Given this list of marker genes DNAJC1, RCN1, ZNF277, GATAD1, ST20, RALGAPA1, WARS1, SCYL2, P2RX4, SYTL1, GRPEL2, FBXL13, MFSD8, CEP120, KLHL24, NUP214, DAPP1, ATXN1, ACAA2, PSTPIP1, CARD19, ENTPD4, PRNP, PIERCE2, SEMA4A, CHD6, RAD51D, ADGRE2, CCDC92, SPG11, WDR33, BBLN, AAK1, RPS6KA5, ARRDC4, ZNF518A, NAP1L1, KLF10 (NCBI Gene Id 7071), GKAP1, TMEM52B, HMGCL, INAFM1, BAZ2B, RGS2, NEAT1, TP53I13, PTPN23, RETREG1, JAK1, MIR223, HCG18, NDE1 (nudE neurodevelopment protein 1), VEGFA, NFAT5, PKD1, CYLD, PTPRE, TRIM38, C1orf74, FTH1P5, STK4, ZNF174, TRIB3 (tribbles pseudokinase 3), GABARAPL1, TCF4, OSBPL11, ZNF536 (zinc finger protein 536), TIMM9, RAB3IP, SERPINB1, RSPH3, ASPHD2, ZMYM5, SH3PXD2A, MBNL2, FSD1L, NBR1, TPM4, CDK19, MYO1B, CREBL2, MGC16275, RIOK3, POC5, CD48, PHGDH, SPMIP4, SCAF4, MIER3, NINJ2-AS1, BCL3, TWIST1, ADORA2A (NCBI Gene Id 135), PCK2, CBS, MAP1LC3B, KLF9, AGO4, LACC1, PSPH, SLC49A4, KRCC1, EIF5, SGTB, CCL3, CTTN, HACE1, NBR2, KDM6B, SH3RF3, SLC25A37, RNF41, CCDC69, TMEM65, IL18RAP, SRD5A3, IDH1, DCAF5, TAPT1, B3GNT5, EXOSC6, ZNF224, ISL2, DUSP6 (dual specificity phosphatase 6), DENND1B, NEK1, JAG1, SGCB, TMIGD3, TIGD7, DDB2, KIZ, ERAP1, ZNF397, KAT2B (NCBI Gene Id 8850), WDFY1, NEDD4, USP27X, ATF5, TNFAIP2, ZNF436, EPB41L3, GNL1, ME1, NCOA1, DBN1, SETD7, ITM2B, RBKS, TRMT13, PHF11, RAP2A, RCSD1, HBP1, STAT2, ASNS, ZNF641, UGGT1, TPK1, DUSP10, PEX1 (NCBI Gene Id 7788), MCEMP1, PPP2R3C, BCL6, CCNG2, EME2, TNFRSF10B, VPS45 (NCBI Gene Id 11312, vacuolar protein sorting 45 homolog), PHLDA2, HCK, MID1IP1, ARAP2, HAGH, ALOX5, MIA2, STX16, ALDH1L2, SLC7A11, EHD1, USO1, INPPL1, GSTM1, SNHG32, RARA, OGT, SLC25A36, PREX1, PLP2, XIAP, KLHL5, IGF2R, TRAPPC6A, ING4, CHKB, TNRC6B, NABP1, N4BP1 (NEDD4 binding protein 1), FAM111A-DT, TTYH3, CDC42BPA, ATAD2B, BST1, CBLB, NNT-AS1, FTH1, SHMT2, GOLGB1, TATDN3, CBX5, ZC3H6, GPR137B, NINJ1, VAMP4, TRIM8, NASP, CARHSP1, PIK3CA, ZCCHC24, ZNF222, GUSBP1, FPR2, N4BP2L2, CCL2, TMEM143, ZNF691, ANTXR2, RFC5, CHMP1B, ARFGAP3, ATG2A, PML, POFUT1, OGG1 (8-oxoguanine DNA glycosylase), AARS1, HSPA13, SLC3A2 (NCBI Gene Id 6520), NDUFC1, NXPE3, SLC22A15, LPIN2, ZSWIM6, RBCK1, TRAPPC6B, LPP, NSD3, SEC24D, TANK, PSIP1, MDM4, BSDC1, FYN, EFHC1, IFIT3, PCNX1, ENSG00000284634, PITX1-AS1, SLFN13, PLCH1, RPL10L, MICAL2, LRP10, MIR570, PLAGL2 (PLAG1 like zinc finger 2), EDEM1, ST3GAL1, SANBR, MAML3, POLG, KLHL2, GADD45A, AGA, IFI16, SP100, VPS35L (NCBI Gene Id 57020), CBX4, YPEL5, KIF21B (kinesin family member 21B), MTMR6, BLVRB, APOOL, GTPBP2, ZMYM2 (NCBI Gene Id 7750), TAFAZZIN, STK3, NCOA3, CYBB, CKMT2-AS1, NBPF9, GFPT1, RAB27A, IRAK4, SLA, PTPRC (NCBI Gene Id 5788), GOLGA1, ZNF623, CPEB4, SYNJ1, INPP5K, CDK17, ERGIC2, NRP1, C10orf143, MIR503HG, ITPR2, NORAD, MOSMO (NCBI Gene Id 730593), ZCCHC8, HIPK2, ADRB1, CEBPB, NPIPA1, PRIMPOL (primase and DNA directed polymerase), PRMT2, FAM111A, BMP2K, TAP1, MEF2A, SESN2, SKA1, GTF2H2C (GTF2H2 family member C), WDR45, IRF2BPL, PDCD5, RNF185, SEMA4C, ZBTB6, CAPG, ALDH6A1, OGA, ASS1, ANXA3, ARRDC3, POLR1HASP, TFE3, ARHGAP11B, ORAI3, ZER1, MED17, RPS6KC1 (NCBI Gene Id 26750), ZNF569, UBE2H, CD55, RNF2, TYROBP, SRD5A1 (NCBI Gene Id 6715), SEMA4B, NBDY, SLC25A24, PPP1R15A, RIT1, TUG1, RBM39, CSTA, TNFRSF1B, NUMB, MAFF, SNTB1, TCEA3, CHD2, GAS6-AS1, UBALD2, ZSCAN29 (NCBI Gene Id 146050), HMCES, SECISBP2L, ST20-AS1, MORC2-AS1, RFX3, ETS1, AKAP13, ARHGEF9, LLGL2, DYNLT3, SEC24A, PCMTD1, VPS39, TMEM135, GLIPR1, CACNA2D4, GPCPD1, ANKRA2, LIPT2-AS1, PPDPF, CSRNP2, DNAJB9, SIPA1L2, PTH2R, SH3YL1, APH1B, HIP1, SLC38A2, USP37, LINC00294, CCDC88C, TRAF3IP3, MARS1, ARHGAP30, SQSTM1, TBL1X, RHOBTB3, CRTC2, SPPL2A, S100P, CLEC7A, LINC00667, S100A11P1, THUMPD3-AS1, DDX59, C11orf21 (NCBI Gene Id 29125), MBD6, TCP11L1, RALGAPA1P1 (NCBI Gene Id 649215), CTH, TGIF1, RCBTB2, BATF3, C18orf32, PLEKHA5, GPATCH2L, SLC30A7, TTBK2, TFAP2E, IFRD1, HLA-F, PTK2B, ZNF252P, DR1, ZBTB46, RNF7, MIR124-1HG, F11R, TM2D1, UGGT2, LRRFIP1, GGPS1, RAB8B, GPR84, PTGR1, ZNF621, PMAIP1 (phorbol-12-myristate-13-acetate-induced protein 1), GPSM3, PKD2, OSBPL7, VPS8, SDC2, TRIOBP, ZNF81, GORAB, SMCR8, ST7L, SPACA9, TIRAP, TMT1A, FAN1, TUBA1A, PRKCA, ITGAV, SEL1L3, SAMD9L, MXD1, TSPAN31, AZI2, CLIC4, ZNF211, RAPGEF2, SRGAP2, DPYSL2, METTL25B (NCBI Gene Id 51093), SNHG33, FAM200C, MANSC1, CXCL8, SH2B3, NFE2L1, CHST7, HLA-A, FOXJ2, LIMK2, ORM1, SEC22C, LMO4, CD69, BIN2, PNPLA8, TNFAIP8L2, YJU2B, LMBRD2 (NCBI Gene Id 92255, LMBR1 domain containing 2), TRIM39, ARHGEF40, NPIPB3, MUTYH, C4orf33, CENPBD1P, KCNE3, MSRB2, HCST, MFSD6, SAMD4B, NOL10, EHBP1L1, CAST, HEBP2, PPIP5K1, TRAF3IP2-AS1, METTL4, TMEM154, SH3BP2, CEP19, CLIP1, NCEH1, GCC1, GOLGA2, EMSY, TALAM1, TMEM87B, CYTH2, FLRT2, RET, BRAP, CHROMR, EFCAB11, WDFY3, FCER1G, SCYL3, PTBP3, TAGAP, SLC12A6, INPP1, GRB10, SNX16, MAPDA, SLC25A40, FILIP1L, GPAT3, RETN (NCBI Gene Id 56729), LINC00205, UTRN, GNS, TXNIP, MYL12A, PLSCR1, ABHD2, BAZ2A, MIRLET7D, FAM3A, RHBDD1, YIPF4, TOR4A, HECA, ZNF671, GNE, TES, AMACR, PLEK, MZF1, AHSA2P, CAPN2, MYO5A, ZRSR2, ARHGAP9, ZNF789, PRAM1, MR1, CHAC1, ZNF230, LINC-PINT, SLC1A4, S100A8, CUL4B, NMRK1, PALS1, PLEKHA8, MOB3C, RECK, TCF12, GABPB1-IT1, SERPINB6, CTBS, CCNB1IP1, STC2, B3GLCT, SMIM14, H1-10, BCL2A1, TUBE1, NOL4L, AKNA, DUSP5, NAGK (N-acetylglucosamine kinase), KSR1, EIF1, AJUBA, RGS14, ERN1, ZSCAN16 (zinc finger and SCAN domain containing 16), CTSS, NFIL3, S100A9, E2F7, PHACTR2, TNFRSF10D, GGACT, ETV5, STIM1, LNPEP, CD40, ALOX5AP, DNAJC10, IL1RN, GBP3, FGD3, BMS1P1, SLC7A1, RPL37, BBS7, DCAF15, IVNS1ABP, FAM131B-AS2, KLHL42, ZNF311, PCBP1-AS1, SEPSECS, BLTP3B (NCBI Gene Id 23074), ATF3, FIG4, TRIQK, SHISA2, USP3, APOLD1 (apolipoprotein L domain containing 1), TMEM80, CPEB2, PDCD4, NHLRC3, TMEM268, NCF1, GARRE1, CCDC50, KRBOX4, ZNF451, SH3GLB1, IDS, PAG1, PTER, OGFRL1, CYP2R1, SSH1, ITPRIP, BTG1, SCAPER, PDE4D, RGS16, FRA10AC1, LIN7A, MAFB, AP1G2, HLA-G, STK39, FOSL2, CELSR1, PLIN2, DDIT4, IL18, SMOX, NIBAN1, UBE2Q2P1, ZNF566, WSB1 (WD repeat and SOCS box containing 1), ACSL1 (NCBI Gene Id 91249), NUDT13, ZBTB41, NAMPT, MLST8, PGD, RNF146, NKIRAS2, ALMS1 (ALMS1 centrosome and basal body associated protein), LETMD1, SLC2A3 (solute carrier family 2 member 3), ARMCX3, RBM4, SYNE3, ARHGAP25, KIF1B, RAB11FIP1, HLA-E, MAP7, PLEKHA1, DZIP3, IFT80, SEPTIN7P13, ZNF652, VSIR, ERRFI1, HTT, FAM149B1, B4GALT4, ARL17A (ADP ribosylation factor like GTPase 17A), KLF4, CSGALNACT2, GPT2, MYO1G, HACD2, FLOT1, NPHP3, KDM7A, OTUD5, MAP3K5-AS2, MORF4L2, GARS1, TIMP2, IL18R1, ZNF133, ZNF18, GAS7, LGALS1 (galectin 1), CHI3L1, RAB4B, CASP8, VLDLR, ZNF274, SHFL, TSC22D3, MINDY2, HBEGF, USP9X, EPOR, DUSP4, IRAG2, CHFR, TAF15, SNHG14, CEP97, WNK1, ZNF33B, SKIL, YIPF6, CCPG1, CNOT7, ITPR1, HDAC9, MAP2K5, CR1, KDM6A, BNIP3L (NCBI Gene Id 9257), SLC16A6, LSP1, TRIB2 (tribbles pseudokinase 2), SEC14L1, CARS1, HLA-J, PGM3, RSRP1, TRIM4, CDKN1A, NQO1, UBE2L6, SUCNR1, MTHFD2, RAB2B, TTC7B, PTP4A3, CCDC71L, PLPP5, TMEM116, TMEM170B, LINC00662, GNB5, MLLT11, PHF21A (PHD finger protein 21A), ARID4A, SSBP2, AKTIP, ATOSA, AP1S2, PSAT1, CD37, G6PD, NUTM2A-AS1, PTPDC1, here is a description of the gene set: CHR-2797 is a novel metalloenzyme inhibitor that is converted into a pharmacologically active acid product (CHR-79888) inside cells. CHR-79888 is a potent inhibitor of a number of intracellular aminopeptidases, including leucine aminopeptidase. CHR-2797 exerts antiproliferative effects against a range of tumor cell lines in vitro and in vivo and shows selectivity for transformed over nontransformed cells. Its antiproliferative effects are at least 300 times more potent than the prototypical aminopeptidase inhibitor, bestatin. However, the mechanism by which inhibition of these enzymes leads to proliferative changes is not understood. Gene expression microarrays were used to profile changes in mRNA expression levels in the human promyelocytic leukemia cell line HL-60 treated with CHR-2797. This analysis showed that CHR-2797 treatment induced a transcriptional response indicative of amino acid depletion, the amino acid deprivation response, which involves up-regulation of amino acid synthetic genes, transporters, and tRNA synthetases. These changes were confirmed in other leukemic cell lines sensitive to the antiproliferative effects of CHR-2797. Furthermore, CHR-2797 treatment inhibited phosphorylation of mTOR substrates and reduced protein synthesis in HL-60 cells, both also indicative of amino acid depletion. Treatment with CHR-2797 led to an increase in the concentration of intracellular small peptides, the substrates of aminopeptidases. It is suggested that aminopeptidase inhibitors, such as CHR-2797 and bestatin, deplete sensitive tumor cells of amino acids by blocking protein recycling, and this generates an antiproliferative effect. CHR-2797 is orally bioavailable and currently undergoing phase II clinical investigation in the treatment of myeloid leukemia. from publication Krige D, Needham LA, Bawden LJ, Flores N, Farmer H, Miles LE, Stone E, Callaghan J, Chandler S, Clark VL, Kirwin-Jones P, Legris V, Owen J, Patel T, Wood S, Box G, Laber D, Odedra R, Wright A, Wood LM, Eccles SA, Bone EA, Ayscough A, Drummond AH (PMID 18701491) species: Homo sapiens Human Gene Set: KRIGE_RESPONSE_TO_TOSEDOSTAT_24HR_UP Genes up-regulated in HL-60 cells (acute promyelocytic leukemia, APL) after treatment with the aminopeptidase inhibitor tosedostat (CHR-2797) for 24 h.